The following is a description of a gene set: Human Gene Set: HP_CLEFT_UPPER_LIP Cleft upper lip A gap or groove in the upper lip. This is a congenital defect resulting from nonfusion of tissues of the lip during embryonal development. studied in species Homo sapiens, and this is the list of marker genes: SMOC1, KANSL1, TRAPPC9, RSPO2, LETM1, GFRA1, DYNC2I2, ESCO2, AMER1, FLNB, B3GLCT, FGD1, NUAK2, TBX4, FGF20 (fibroblast growth factor 20), SIX3, NEK1, GPC3, GPC4, CYP26C1, IFT80, FRAS1, ARHGAP31, TP63, DLX4 (NCBI Gene Id 1751), SEMA3E, RIPK4, CILK1, CHUK, POLR1A, JUP, COLEC10, GAS1, DLL1, CHD7, TFAP2A, RPS19, DYNC2H1, CCN2, GRIP1, BMP4, KIF7, HOXD13, FZD2, CPLANE1, NSD2, ASXL1, EPG5, PLCH1, SLC29A3 (NCBI Gene Id 8072), MKS1, WDR35, MSX2, DISP1 (dispatched RND transporter family member 1), PAX3, WLS, FGF8, TGDS, GLI2, SMAD4, PIGV, TCTN2, ITGA8, DEAF1, PHF8, EVC2, SF3B2, SMO, SUMO1, POLR1C, RAB5IF, GDF11, CTBP1, PTCH1, CPLX1, GLI3, MEOX1, WNT9B, TCTN3, KAT5, CDH1, BCOR, KDM6A, GREB1L, PORCN, ALX3, LMX1B, DDX3X, IQSEC2 (IQ motif and Sec7 domain ArfGEF 2), POMT1, INTU, TCOF1, SMPD4, SMC1A, TMCO1, H4C3, EFNB1, NBN, RPL5, ZSWIM6 (NCBI Gene Id 57688), TGIF1, CDON, SPECC1L, TXNL4A, ACTB, POMT2, GRHL3, FOXC2, MSX1, FKRP, HYLS1, RET, SF3B4, VAX1, NIPBL, IRF6, SPOP, NAA10, LARGE1, EVC, CRIPTO, DYNC2LI1, MID1, NSDHL, CEP120, NODAL, TAPT1, MEIS2, FKTN (NCBI Gene Id 2218), RPGRIP1L, GJA1, PIGN, FLII, POLR1B, MASP1, KMT2D, OFD1 (OFD1 centriole and centriolar satellite protein), NECTIN1, WNT3, RAI1, NELFA, STIL, PIGG, ZIC2, DYNC2I1, PHGDH, FOXH1, YAP1, POLR1D, DHODH (NCBI Gene Id 1723), FGFR1, STAG2, CC2D2A, DDX59, FREM2, SHH, PROKR2, FGFRL1, MED12, COLEC11